Given this list of marker genes Sorl1 (NCBI Gene Id 72910), Gpld1, Apoc3, Plin5, Pik3cg, here is a description of the gene set: Mouse Gene Set: GOBP_NEGATIVE_REGULATION_OF_TRIGLYCERIDE_CATABOLIC_PROCESS studied in species Mus musculus Any process that decreases the frequency, rate, or extent of the chemical reactions and pathways resulting in the breakdown of triglyceride.